Given this list of marker genes Cdip1, Gfap, Borcs7, Litaf, Bloc1s2, Borcs5, Bloc1s1, Litafd, Borcs6, Kxd1, Borcs8, Snapin, here is a description of the gene set: species: Mus musculus The side (leaflet) of the lysosomal membrane that faces the cytoplasm. Mouse Gene Set: GOCC_CYTOPLASMIC_SIDE_OF_LYSOSOMAL_MEMBRANE